The following is a description of a gene set: A single cancer cell contains large numbers of genetic alterations that in combination create the malignant phenotype. However, whether amplified and mutated genes form functional and physical interaction networks that could explain the selection for cells with combined alterations is unknown. To investigate this issue, we characterized copy number alterations in 191 breast tumors using dense single nucleotide polymorphism arrays and identified genes with copy number gain organized into 30 amplicons. Amplicons were distributed unequally throughout the genome. Each amplicon had distinct enrichment pattern in pathways, networks, and molecular functions, but genes within individual amplicons did not form coherent functional units. Genes in amplicons included all major tumorigenic pathways and were highly enriched in breast cancer-causative genes. In contrast, genes with somatic mutations in breast cancer were distributed randomly over the genome, did not represent a functionally cohesive gene set, and were relatively less enriched in breast cancer marker genes. Mutated and gained genes did not show statistically significant overlap but were highly synergistic in populating key tumorigenic pathways including transforming growth factor beta, WNT, fibroblast growth factor, and PIP3 signaling. In general, mutated genes were more frequently upstream of gained genes in transcription regulation signaling than vice versa, suggesting that mutated genes are mainly regulators, whereas gained genes are mostly regulated. ESR1 was the major transcription factor regulating amplified but not mutated genes. Our results support the hypothesis that multiple genetic events, including copy number gains and somatic mutations, are necessary for establishing the malignant cell phenotype. Human Gene Set: NIKOLSKY_BREAST_CANCER_8Q12_Q22_AMPLICON Genes within amplicon 8q12-q22 identified in a copy number alterations study of 191 breast tumor samples. from publication Nikolsky Y, Sviridov E, Yao J, Dosymbekov D, Ustyansky V, Kaznacheev V, Dezso Z, Mulvey L, Macconaill LE, Winckler W, Serebryiskaya T, Nikolskaya T, Polyak K (PMID 19010930) studied in species Homo sapiens, and this is the list of marker genes: MTERF3, TP53INP1, MATN2, CCNE2, LY96, UBE2W, CPQ, SLC26A7, DCAF13, IMPA1, NDUFAF6, GDF6, RALYL, STAU2, SDCBP, TSPYL5, CYP7A1, ODF1, STMN2, KCNB2, OTUD6B, NKAIN3, ESRP1, DECR1, RGS22, RIMS2, CIBAR1, RDH10, HEY1, POLR2K, CFAP418, CRISPLD1, TMEM70, RIPK2, FBXO43, SNX16, EYA1, RPL30, IL7, NECAB1, YWHAZ, NIPAL2, ERICH5, JPH1, OSR2 (NCBI Gene Id 116039), NBN, ZNF706, CALB1, ZBTB10, KLF10, SNX31, KCNS2, GEM, ASPH, SBSPON, ATP6V1C1, DPY19L4, VPS13B, FABP9, RNF19A, XKR9, RUNX1T1, ZFAND1, ELOC, MRPS28, TRAM1, COX6C, RIDA, CHMP4C, TMEM67, TTPA, PMP2, PI15, FABP5, SPAG1, PLEKHF2, SLCO5A1, GRHL2, SDC2, PTDSS1, PAG1, YTHDF3, SLC25A32, HNF4G, GDAP1, PKIA, PIP4P2, PDP1, CLVS1, SLC10A5 (NCBI Gene Id 369015), TMEM64, ZC2HC1A, TPD52, RPL7, AZIN1, BAALC, SULF1, RPSAP47, MSC, PRDM14 (NCBI Gene Id 63978), MMP16, INTS8, VIRMA, TERF1, MTDH, CHD7, STK3, CNBD1, UBXN2B, UQCRB, CTHRC1, GGH (gamma-glutamyl hydrolase), OSGIN2, NCOA2, POP1, PEX2, ZFHX4, PABPC1, ANKRD46, NSMAF, LAPTM4B, TRPA1, CDH17, RBM12B, FZD6, FABP4, LACTB2, RPL7P9 (NCBI Gene Id 653949), RAB2A, DCAF4L2, ZNF704, RAD54B